Given this list of marker genes CLSTN2, ZRANB1, PIGX, PRKAR1A, NR3C1, KLF7, GDPD5, PGM5 (NCBI Gene Id 5239), UBXN1, KCNJ13, ZNF479, SDC3, CNOT7, SATB1, ATRNL1, UBE2H, PSMD10, MTX3, SUCLG2, SET, DSTN, ARHGEF15, ITIH4, MYPN, MGAT1 (NCBI Gene Id 4245), CYB561, CENPN, DGKK, RIMS1 (regulating synaptic membrane exocytosis 1), DAAM2, SHANK2, GALNT15 (polypeptide N-acetylgalactosaminyltransferase 15), ZFHX3, MICAL3, ZNF716, SEMA6D, DCAF7, NUP50, POGZ, DOCK7, TLCD3A, HILPDA, COL4A6, DDX3X, UBE2D3, SPTLC2, DCLK1, GPR137C, TUSC1, DDX3Y, B3GNTL1 (UDP-GlcNAc:betaGal beta-1,3-N-acetylglucosaminyltransferase like 1), HMGA2, NFAT5 (nuclear factor of activated T cells 5), ST6GALNAC2, FUT3, CCDC92, XRCC2, RIMBP3, STK26, ADAMTS6, SLC31A1, XPO7, JAM3, FZD5, TTPAL, MAP2, SRSF6, ING3, FAM227A, IQSEC2, GPC4, RAB3B, TIMP2, CERKL, CEP128, RIMBP3C, ZNF704 (NCBI Gene Id 84737), SHISA6, ELF4, CTTNBP2NL, CLN5, EMX2, RIMBP3B, FBXW7, SH3PXD2B, PTPRO, TNRC6C, RAP1B, LDAF1, ARNT2, COL4A4, TSHZ2, PHF24, AZI2, NUAK2, MTMR4, RHBDF1, ARL15, SOX5, YWHAZ, C1orf35, N4BP2, SLC6A17, RHOJ, CCDC141, ROBO1, KLHL14 (kelch like family member 14), RHOQ, POTEF, TXNIP, PAK5, TMEM233, SCN2A, TGM6, CUX1, CCND3, TKTL2, TOP3A, TBC1D22B, DARS1, XIRP2, MARK1, CHST14, OTUD6B, KLHL32, NALCN, MARCKSL1, here is a description of the gene set: species: Homo sapiens from publication Chen Y, Wang X (PMID 31504780) Genes predicted to be targets of miRBase v22 microRNA hsa-miR-4701-5p in miRDB v6.0 with MirTarget v4 prediction scores > 80 (high confidence targets). Human Gene Set: MIR4701_5P